The following is a description of a gene set: Human Gene Set: GSE40666_NAIVE_VS_EFFECTOR_CD8_TCELL_DN from publication Gil MP, Ploquin MJ, Watford WT, Lee SH, Kim K, Wang X, Kanno Y, O'Shea JJ, Biron CA (PMID 22968462) Type 1 IFNs can conditionally activate all of the signal transducers and activators of transcription molecules (STATs), including STAT4. The best-characterized signaling pathways use STAT1, however, and type 1 IFN inhibition of cell proliferation is STAT1 dependent. We report that type 1 IFNs can basally stimulate STAT1- and STAT4- dependent effects in CD8 T cells, but that CD8 T cells responding to infections of mice with lymphocytic choriomenigitis virus have elevated STAT4 and lower STAT1 expression with significant consequences for modifying the effects of type 1 IFN exposure. The phenotype was associated with preferential type 1 IFN activation of STAT4 as compared to STAT1. Stimulation through the TCR induced elevated STAT4 expression, and STAT4 was required for peak expansion of antigen-specific CD8 T cells, low STAT1 levels, and resistance to type 1 IFN-mediated inhibition of proliferation. Thus, a mechanism is discovered for regulating the consequences of type 1 IFN exposure in CD8 T cells, with STAT4 acting as a key molecule in driving optimal antigen-specific responses and overcoming STAT1-dependent inhibition of proliferation. species: Homo sapiens Genes down-regulated in CD8 T cells: naïve versus day 8 after LCMV infection., and this is the list of marker genes: FES, TNFSF11, ARAP3, TGIF1, LYSMD2, UBE2F, EEA1, FRMD4A, EYA2, SH3GL3, CX3CR1, SLC39A6, CRTAP, ACYP2, ARL4D (NCBI Gene Id 379), IFITM10, PTPN22, MYLIP, NFIC, ABTB3, AVEN, EVI2B, ESYT1, PLEKHA3, AGFG1, MTHFD1L, TOR4A, GRHL1, MAPK10, HS6ST2, MYO7A, FZD5, KBTBD11 (NCBI Gene Id 9920), SPRY2, IRF5, FKBP5, GBP4 (NCBI Gene Id 115361), HSP90B1, USP20, S100A10, FARP1, IL27RA, PLS1, LAMTOR4, VCL, AIM2, ST8SIA6, TRPM4, RP9, MAP3K5, ACTR3B, KIAA0930, APPL2, ATP8B4, RNASET2, FURIN, SCRN2, RAB31, MFSD14A, TSHZ3, PRKAR2A, TMEM126A, TENT5A, COPS7A, PRF1, LCLAT1, TMEM64, PLAC8, KLHL21, SLC38A1, TBC1D16, MYO1F, BSCL2, CATSPERD, CEBPZOS, CFAP20DC, TRAF5, SCARB1, SOCS3, OSBPL5, DIPK1B, RAB19, TMEM140, TNFRSF1B, RELL2, RNF144A, DTNBP1, RAB32, ABHD4, GPR183, FCER1G, ASNS, LEPROT (leptin receptor overlapping transcript), LGALS1, SIAE, SOX13, SOAT1, INHA, PPIE (NCBI Gene Id 10450), MACROD1, DPY19L1, PHACTR2, RNF135, MCRIP2, MYO1E, G6PC3, PLD1, MYB, CXCR6, PGM1, SLCO3A1, F2RL2, SMCO4, MXRA8, EPSTI1, AK7, NARS1, ABHD17A, ISYNA1, NAAA, TRPM6, ZNF23, PELI2, MYD88, LHPP, MID1IP1, SLBP, PDE2A, AKR1E2, POGLUT3, LITAF, TRPV2 (transient receptor potential cation channel subfamily V member 2), IL2, NCMAP, GABRR2, ECI1 (enoyl-CoA delta isomerase 1), DTX4, CARD10, FKBP2, PLEKHA2 (NCBI Gene Id 651347), AHR, SLC4A7, RNF43, PKP3, SNX2, NT5E, ID2, KCTD12, GZMK, PSME1, SHE, AMZ1, PON3, GPN1, LGALS3BP, VTI1B, SLC22A15, RHOD, LYN, MYC, RCN1, TTC32, CCDC126, ICOS, RNF32, XCL1, FASLG, NSMAF, DHRS11, HGSNAT, TTYH2, IL13, BLK, ANXA11, TRIP10, LIN7A, GRWD1, ANKRD54, C1orf122, CRELD2, YDJC, PRR15, ARHGAP26 (Rho GTPase activating protein 26), PXDC1, GDPGP1, B4GALNT4, ABCB1, APOBR, SEMA4A, CTSW, PLSCR1, DNAJA4, KLRD1, NCEH1, CTSC, NXT2, LPAR6, MAGED1, COMTD1, FHL2